The following is a description of a gene set: Genes predicted to be targets of miRBase v22 microRNA hsa-miR-5684 in miRDB v6.0 with MirTarget v4 prediction scores > 80 (high confidence targets). from publication Chen Y, Wang X (PMID 31504780) species: Homo sapiens Human Gene Set: MIR5684, and this is the list of marker genes: KPNA4, FYB1, FST, MIB1, ANKIB1, ARIH1, ZNF449 (NCBI Gene Id 353278), GTF2A1, CNTN1, CRYM (NCBI Gene Id 1428), MED26 (mediator complex subunit 26), CLHC1, NKX3-2, RCOR3, ADAM2, EFHC2 (NCBI Gene Id 80258), CBX8, PPM1H, AP4B1, NHSL1, RGS4, SEMA3A, KLHL24, LILRA1, ACSL4, MRTFB, ZDHHC2, XRN2, B3GNT2 (NCBI Gene Id 55878), CXXC4, TNPO2, ARL17A, ADAMTS1, PAPPA, ATG14, RASA2, TMX1, SNTB1, TNFSF18, RPS6KL1, HIVEP2